Given this list of marker genes ATF3, PTPRD, FGFR2, SCD5, CPM, MYO10, SNRPN, SPTBN1, VEPH1, ACTG1, PPDPF, SLC4A4, CITED4, C12orf75, ERBB3, CYP3A5, CAV2, MYADM, ITGB8, SYNJ2, SLC37A4, CLIC6, RASSF4, AQP1, ZFHX4, TACSTD2, CLDN10, BACE2, CCND1, LGALS3BP, LAMP2, SOX4, ITGB5, CCN2, TEAD1, ANXA5, VEGFA, TNFRSF12A, ANXA4, LAMA5, KRT7, CLDN3, SLPI, NECTIN2, SPINT2, SLC5A1, CALM2, MYO1C, PROM1, ITGB1, TESC, MAGI1, TPM4, BMP2, NR2F2 (nuclear receptor subfamily 2 group F member 2), GABRP, LAMC1, FSTL3, MMP7, CDKN1C, NEDD4L, KRT19, NFIC, MAFF, CHST4, CFTR, NUAK2, BEX3, ABCC3, SLC12A7, CDC42EP1, LRP10, FZD1, PKHD1, EPB41L1, CTBP2, EPCAM, SLC12A2 (solute carrier family 12 member 2), ALKAL2, C6orf132, WEE1, FXYD2, WFDC2, CREB5, SHROOM3, EGR1, BCL2L1, ABLIM1, CLDN4, TM7SF3, KIFC3, TM4SF4, AGT, NIBAN2, FOXA2, AMOTL2, EPHA2, LAMC2, ARRDC2, SPP1, ACTN4, WNK2, HOMER2, DDR1, PLXNB2, OCLN, RBPMS, PTPRF, TNKS1BP1, THSD4, BICC1, SOD3, FAM110C, TOB1, RAB3IP, CAMK2N1 (calcium/calmodulin dependent protein kinase II inhibitor 1), ONECUT2, SPINT1, CRIM1, CXCL6, SERPINA5, BIRC3, TMPRSS2, ATP1A1, PERP, COL27A1, PAWR, SHANK2, DEFB1, PBX1, ZBTB20, GOLM1, PLEKHB1, PWWP3B, DSG2, PMEPA1, CCDC198, PTPRK (protein tyrosine phosphatase receptor type K), ERICH5, DCDC2, DSTN, KIF12, SDC1, SPATS2L, TPM1, EMP2, AKR1C2, S100A6, CLMN, TOB2, GTF2I, ELF3, TPPP3, GLIS3, DSP, CXADR, MUC6, RHBDF1, TRNP1, CCN1, NHSL3, C1orf198, S100A14, ALCAM, CD59, CLDN1, ENAH, CD151, SFRP5, SH3YL1, LAD1, FAM171A1, AFDN, PLXNB1, CTDSPL, RAP1GAP (RAP1 GTPase activating protein), CRYAB, TM4SF1, SLC6A19, NFIB, LIF, SOX9, ATP1B1, CHST9, SNHG14, ANKRD1, WWC1, KRT8, LGALS4, CXCL8, WWTR1, SCGN, KCNJ16, ANXA13, COBL, VCAN, ANXA2, CLDN7, FAIM, CD24, FGFR3, SDC4, CKB, CTNND2, SLC17A4, LLGL2, GDF15, ANXA3, KLF5, TTN, MYRF, CDH1, ANPEP, PARD6B, TP53INP1, SORBS2, KRT18, GSTP1, ALDH3A2, here is a description of the gene set: Human Gene Set: AIZARANI_LIVER_C7_EPCAM_POS_BILE_DUCT_CELLS_2 species: Homo sapiens from publication Aizarani N, Saviano A, Sagar, Mailly L, Durand S, Herman JS, Pessaux P, Baumert TF, Grün D (PMID 31292543)